The following is a description of a gene set: from publication Chen Y, Wang X (PMID 31504780) Genes predicted to be targets of miRBase v22 microRNA hsa-miR-6516-3p in miRDB v6.0 with MirTarget v4 prediction scores > 80 (high confidence targets). studied in species Homo sapiens Human Gene Set: MIR6516_3P, and this is the list of marker genes: ERBB4, RAB11FIP2, NAA35, NFIB, CCDC170, HACD4, CSPP1, TRPS1, TSC22D2, HIPK3, HERC1 (HECT and RLD domain containing E3 ubiquitin protein ligase family member 1), DCDC2, GOLT1B, KLHL2, MYH11, ADAMTS17, AFF4, PDE10A, RECK, PCDH20, CDKL2, ANO3, ARHGAP42, ANKRD20A4P, ROBO2, HACE1, TLL1, RBBP7, KMT2E (lysine methyltransferase 2E (inactive)), JPH1, SMURF2, FBXO47, ZNF426 (zinc finger protein 426), HDAC6, ATL3, BAZ1A, DDX23, ABCA8, SH3BGRL2, PDE1C, RFX7, ARFIP1, CHL1, PTPRQ, PHF21A, MARCHF5, CDK8, ATP2A2, MSTN, ZNF763, TMEM100, FAM76A, ITGB6, ANKRD20A2P, PRKAR2B, TMTC3, STEAP2, CLVS1, ZNF439, PHTF2, PI4KA, ATF2, GYPA, ZFAND1, ANKRD20A3P, MEGF11, LPCAT2, LRP11, ZNF607 (NCBI Gene Id 84927), GFM2, KHDRBS2, GNG2, NRIP1, ANOS1, ZNF22, PPP5D1P, TMOD3, ZGRF1, METTL15, TLK1, MYO5C, MANEA, CHD9, ABHD16A, ARRDC3 (NCBI Gene Id 57561), TAP2, ZNF207, ZNF268, ADCY7, G3BP2, ZBTB10, NR1D2, KLHL15, PRELID3B, PARD6B, MRPS23, QKI, PRKG1, ZNF410 (NCBI Gene Id 57862), COL25A1, LRRC7, EIF4G1, ZBTB20, MAP3K20, TARP, CADM2, PCNP, TRHDE, SMC2, POLR3E, DYNC2I1, TM9SF3, CA5B, HMGN4, ANKRD20A1, ZNF718, ZNF440 (NCBI Gene Id 126070), PTGR2 (NCBI Gene Id 145482), CITED2, FAM210B, RAD51AP1, RLF, DDIT4, ZNF136, SUMO4, HTATIP2, EPHA5, FGF18 (NCBI Gene Id 8817), GPR12 (NCBI Gene Id 283535), SAMD12, DPY30, PAX8, FAM133A, DMD, ADAM10, ZNF292, ZNF563, ARL13B, STK32B, MMUT, ZNF124, MINDY2, AVL9, FUT9